Given this list of marker genes Enpep, Mpp7, Ptpn9, Sema3a, Edil3, Jph1, Ces1f, Bcor, Rad1, Neto2, Ebf1 (early B cell factor 1), Ing2, Nkrf, Ccdc88a, Rrm2b, Muc21 (mucin 21), Htr5a, Cadm1, T2, Bnc2, Ddx18, Scara5, Rraga, Wdr37, Bod1l, Thap2, Minpp1, Sirpb1c, Cfdp1, Ggnbp2, Nr1d2, Tfdp2, Tnpo3, Akap11 (A kinase anchor protein 11), Proser1, Atad2, Nxph2, Vps50, Frmd6, Rce1, Mrpl17, Phox2b, Exosc1, Nr5a2, Pknox1, Med30, Efna5, Pogz, Ythdf2, Tnfrsf9, Rora, Sntb2, Hoxb2, Zfp148, Phf8, Zfp182, Cilk1, Mab21l1, Pcdh9, Gdpd1, Adra1a, Pam, Mbtd1, Ctsc, Dnajc10, Glra2, Cdk6, Kat6b, Psd3, Ppp4r3b, Pola1, Tfap2a, Rgs13, Pde3b, Pcdh7, Clta, Cul2, Dzip3 (NCBI Gene Id 70183), Six1, Crem, Arhgef12, Pou3f2, Lancl3, Fut9, Slc39a9, Ap5m1, Prrx2, Ncbp3 (NCBI Gene Id 97706), Rab10, Adam22 (a disintegrin and metallopeptidase domain 22), Arel1, Ccn3, Tiprl, Insr, Ano3, Grk5, Rwdd2b, Aak1, AI182371, Cd200l1, Sf1, Ikbip, Iqsec2, Suco, Hook3, Gpr174, Dcaf10, Ftsj1 (NCBI Gene Id 54632), Rspo3, Dnajc12, Atp11b, Dipk2a, Spag9, Sod2, Zfp11, Reps2, Gabra3, Sirpb1b, Tnfaip3, Scin, Map2k1, Mecp2, Senp8, Wdfy4, Elavl2, Sertad2, Ddx17 (NCBI Gene Id 97974), Nphs2, Mapkapk2, Klhl15, Snx10, Zkscan8, Top2a, Ube2e3, Sytl4, Dr1, Tenm4, Wdr26, Kctd14, Syt4, Mettl25b, B4galt6, Tmem168, Semp2l2a (NCBI Gene Id 234083), Lin28b, Hipk1, Arid2, Zfhx4, Rapgef2, Junb, Ahi1, Pank3, Cacnb4 (calcium channel, voltage-dependent, beta 4 subunit), Hivep2, Zfp871, Rapgef6, Fgf16, Ube2c, Slc35d3, Sbno1, Mamdc2 (MAM domain containing 2), Ago2, Tmem41b, Mprip, Hectd2, Igsf1, Zbtb6, Zfp709, Ostm1, Npr3, Slitrk5, Rbms3, Trp53bp2, Pik3r3, Cldnd1, Erbb4, Nup98, Elac1, Pou2f1, Nelfa, Cep350, Tpm1, Enpp4, Trpc3, Arhgap20, Cdyl2, Zfp704, Mier1, Cd38, Cetn3, Rap2c, Map3k7, Rpia, Prrg3, Tbc1d2b, Rasa2, Osbpl3, Robo1, Dpy30, Lrrc4c, Adcy2 (adenylate cyclase 2), Atad2b, Onecut2, Gabra1, Synj1, Inpp5f, Gdap1l1, Gria4, Crebrf, Mosmo, Baiap2l1, Wdr36, Mapre3, Uhrf2, Usp37, Mylip, Msl2, Mxi1, Ppp3cb, Tchh, Slc4a4, Lrrc63, Mmp12, Ctsa, Cop1, 4921524J17Rik, Dstyk, Etnk1, Adgrg1, Asxl2, Fsd1l, Mrc2, Ccdc85b, Arid4a, Cwc22, Dennd6a, Arhgap19, Dync1li2, Lrig1, Pcsk5, Hlf, Marcksl1, Nrep, Errfi1, Canx, Klri2, Armh3, Bpnt2, Pde7a, Wdr12, Map3k1, Lgr4, Max, Tnfsf9, Brinp3, Pip4p2, Npas3, Smg1, Dnaaf9, Myef2, Znfx1, Slc38a10, Krtap4-2, Pcnp, Stx12, Larp1, Dpy19l1, Kif5b, Zc3h12c, Ipmk, Tbc1d8b, Cbx7, Gnb5, Papolg, Esp18, Arl15, Mro, Ppm1d, Celf2, Il13ra1, D16Ertd472e, Snap25, here is a description of the gene set: from publication Chen Y, Wang X (PMID 31504780) studied in species Mus musculus Mouse Gene Set: MIR_743A_3P Genes predicted to be targets of miRBase v22 microRNA mmu_miR_743a_3p in miRDB v6.0 with MirTarget v4 prediction scores > 80 (high confidence targets).